Given this list of marker genes Rgs8, Chrm1, Chrm2, Itpr1, Plcb1, Cdk5r1, Orai1, Gna11, Prkcb, Rgs10, Gnai2, Chrm3, Hrh4, Chrm5, Trpc1, Hrh3, Chrm4, Oprm1, Gnaq, Stim1, Anxa7, here is a description of the gene set: Mouse Gene Set: GOBP_G_PROTEIN_COUPLED_ACETYLCHOLINE_RECEPTOR_SIGNALING_PATHWAY studied in species Mus musculus A G protein-coupled receptor signaling pathway initiated by a ligand binding to an acetylcholine receptor on the surface of a target cell, and ends with regulation of a downstream cellular process, e.g. transcription.